Given this list of marker genes NPM1, SNRPD1, SRSF2 (serine and arginine rich splicing factor 2), NCL, ZNF146, MYB, KPNA2, NOLC1, CCNO, UNG, here is a description of the gene set: Human Gene Set: MODULE_457 Genes in the cancer module 457. studied in species Homo sapiens